The following is a description of a gene set: Mouse Gene Set: GOBP_METANEPHRIC_GLOMERULAR_MESANGIUM_DEVELOPMENT The process whose specific outcome is the progression of the metanephric glomerular mesangium over time, from its formation to the mature structure. The metanephric glomerular mesangium is the thin membrane connective tissue composed of mesangial cells in the metanephros, which helps to support the capillary loops in a renal glomerulus. species: Mus musculus, and this is the list of marker genes: Egr1, Wt1, Pdgfb, Cd34, Pdgfrb